Given this list of marker genes Rps27a, Cdc26, Psmc3, Mad2l1, Nde1, Psma6, Anapc15, Psmd12, Clasp1, Tuba1c, Hdac8, Nup133, Tuba4a, Nup85, Dync1li2, Spc24, Rad21, Ndc80 (NDC80 kinetochore complex component), Plk1, Dynll1, Psma5, Cenpq, Tuba8, Psmb4, Psma4, Ppp2r5d, Cenpe, Cenpa, Zwilch, Ube2e1, Psmd1, Psma3, Anapc2, Ube2s, Cenpn, Tuba1b, Smc3, Nudc, Tubal3, Mad1l1, Cenpm, Psmd13, Tubb6, Ndel1, Psmc5, Anapc7, Stag1 (NCBI Gene Id 20842), Tubb4b, Psmc1, Ppp2r5b, Ubb, Cenps, Psmc4, Ube2d1, Psma1, Ppp2r1b, Kif2c, Psma7, Psmd7, Mis12, Psma2, Kif2b, Cenpt, Aurkb, Itgb3bp, Psmc2, Seh1l, Tubb4a, Tuba1a, Psmc6, Psmb6, Cenpu, Psmb5, Anapc10, Kntc1, B9d2, Tuba3b, Ska1, Xpo1, Cdc23, Tubb2b, Ppp2r5a, Psmd6, Psmb7, Ube2c, here is a description of the gene set: Reactome Pathway: Separation of Sister Chromatids electronically inferred by orthology from the curated human pathway species: Mus musculus This event has been computationally inferred from an event that has been demonstrated in another species.<p>The inference is based on the homology mapping from PANTHER. Briefly, reactions for which all involved PhysicalEntities (in input, output and catalyst) have a mapped orthologue/paralogue (for complexes at least 75% of components must have a mapping) are inferred to the other species. part of: Mitotic Anaphase